The following is a description of a gene set: Human Gene Set: REACTOME_DNA_DAMAGE_RECOGNITION_IN_GG_NER species: Homo sapiens DNA Damage Recognition in GG-NER, and this is the list of marker genes: RAD23B, COPS7A, COPS7B, CETN2, COPS4, INO80E, COPS5, TFPT, RUVBL1, CUL4B, GPS1, UBA52, CUL4A, ACTR5, NFRKB, INO80B, COPS6, UBB, RPS27A, ACTR8, COPS3, DDB2, COPS8, COPS2, PARP1, ACTL6A, DDB1, RBX1, INO80C (NCBI Gene Id 125476), INO80, ACTB, INO80D, XPC, MCRS1, UBC, PARP2, YY1, RAD23A